Given this list of marker genes BDKRB2, AGT, JAK2, ARAP1, EDNRB (NCBI Gene Id 3282), here is a description of the gene set: Human Gene Set: GOMF_TYPE_1_ANGIOTENSIN_RECEPTOR_BINDING Binding to a type 1 angiotensin receptor. studied in species Homo sapiens